Given this list of marker genes SLC25A20, IVD, LYRM7, HADHA, MMACHC, ACAD8, NADK2, PGM2L1, OBSCN, TANGO2, CPT2, MCEE, ACAD9, SLC52A1, ABCD4, MMAB, HADH, ATAD1, LMBRD1, GCDH, COX16, ETHE1, ACADS, here is a description of the gene set: Abnormal circulating acylcarnitine concentration Human Gene Set: HP_ABNORMAL_CIRCULATING_ACYLCARNITINE_CONCENTRATION Any deviation from the normal concentration in the blood circulation of an acylcarnitine, which is produced by reversible esterification of the 3-hydroxyl group of carnitine. studied in species Homo sapiens